The following is a description of a gene set: Human Gene Set: GOMF_TYPE_2_FIBROBLAST_GROWTH_FACTOR_RECEPTOR_BINDING Binding to a type 2 fibroblast growth factor receptor (FGFR2). species: Homo sapiens, and this is the list of marker genes: FGF7, FGF18, FGF10, FGF8, FGF17